Given this list of marker genes Ube2g2, Ubac2, Erlec1, Edem2, Yod1, Os9, Edem1, Ube2j1, Bcap31, Derl2, Svip, Derl3, here is a description of the gene set: Any process that modulates the frequency, rate or extent of retrograde protein transport, ER to cytosol. studied in species Mus musculus Mouse Gene Set: GOBP_REGULATION_OF_RETROGRADE_PROTEIN_TRANSPORT_ER_TO_CYTOSOL